Given this list of marker genes Skp1 (NCBI Gene Id 76591), Enpp4, Ank, Kitl, Cd36, Kdm7a, Lbh, Ar, Mmp19, Efna5, Exoc6b, Nkain3, Cic, Purb, Pip4k2a, Taf7, Zfp719, Homer1, Rint1, Ro60, Adam34, Hoxa2, Kcnj14, Crebrf, Gnao1, Nxnl1, Zfp955b, Mysm1, Grip1, Cbln2 (NCBI Gene Id 225810), Rab7, Msl1, Sdc2, Ikzf3, Thsd4, Nrxn1, Ints8, Med14, Ms4a6c, Pfkfb4, Pgbd1 (piggyBac transposable element derived 1), Tmtc1, Cxcl9, Ednrb, Siglecg, Emb, Mfhas1 (malignant fibrous histiocytoma amplified sequence 1), Garem1, Gdf6, Bnc2, Tent5a, Grm3, Palld, Retn, Hlf, Adora2b, Slc7a11, Rsad2, Zic4, Dmd, Apobec3, Scn3a, Med13, Cln5, Oscp1, Pak3, Sav1, Ctps2, P2rx7, Zmynd8, Gtf2h2, Kcnj13, Bcl11a (BCL11 transcription factor A), Gng2, Cdc42ep3, Adcyap1, Ints12, B3gat1, Cycs, Car13, Pamr1, Scn8a, Map2k7, Prg4, Zbtb7a, Chpt1, Socs6, Sult6b1, Sc5d, Rabgap1l, Cacul1, Slc4a10, Dcdc2a, Gabpa, Fyttd1, Usp9x, Cst12, Zbtb20, Fbxl2, Col23a1, Srsf5, Cdh7, Fosb (FBJ osteosarcoma oncogene B), Sp100, Xcr1, Cask, Lepr, Wwc2, Ptchd4, Zmiz1, Ccr9, Grem1, Rp2, Uqcc4, Slc22a13, Ebf1, Brinp1, Dbx2, Itgb6, F5, Zdhhc21, Ppp1r3a, Slc20a1, H2bw2, Nmur2, Kdm5b, Npy2r, Rell1, Faxc, Frk, Slain2, Zbtb4, Csmd1, Rgs20, Ahdc1, Ythdf1, Gria2, Klrb1a, Ntrk3, Maml2, Zfp704, Pde4d, Rabgap1, Desi1, Kcna4, Ghr, Elovl6, Rab14, Meig1, Dcstamp, Hmcn1, Tbx3, Pde6c, Ajap1, Cdc14b, Ceacam2, Ciita, Ago4, Ncam1, Slc24a2, Pgr, Ttyh1, Klf8, Gcnt1, Synrg (NCBI Gene Id 97682), Leprotl1, Diaph2, Cited2, Phf14, Mapk8, Ercc1, Tnrc6b, Foxp2, Nxpe3, Wif1, Cdk5r1, Sobp, Cnih3, Sppl2a, Zfp329, Bahcc1, Hs3st3b1, Pik3r3, Scyl3, Hivep3, Aldh9a1 (NCBI Gene Id 56752), Ppargc1a, Trim52, Mosmo, Ndn, Hars2, Chmp4c, Eif4ebp2, Cep170, Urgcp, Tmcc1, Vcf1, Jakmip2, Foxp1, Arrdc3, Vps16, Kera, Enpp6, Fam124b, Ugcg, Pggt1b (NCBI Gene Id 70264), Foxb1, Zfp65, Ids, Plek2, Selp, Cdcp1, Klrb1f, Cdkn1a, Des, Cacna2d1, Aldh6a1, Srebf1, Loxl4, Rufy2 (RUN and FYVE domain-containing 2), Lama3, Pde1c, Fgf13, Zfp74, Gpr153, Klf9, Cmip, Tubal3 (NCBI Gene Id 238463), Ube2r2 (ubiquitin-conjugating enzyme E2R 2), Sspn, Kcnv1, Csde1, Rbfox3 (NCBI Gene Id 65119), Zfp950, Foxd1 (NCBI Gene Id 268693), Ebf2 (early B cell factor 2), Cadm2, Prkg1, Rasgrp3 (RAS, guanyl releasing protein 3), Dvl2, Fut9 (NCBI Gene Id 14348), Smad4, Osbpl8, Ly6m, Ncbp2, Chmp2b, Git2, Apobec1, Sult1c1, Lima1, Tfap2b, Qki, Mtarc1, Rpgrip1, Sirt2, Rbbp9, Atp2b4, Cdh4, Zyg11b, Ntrk2, Tmem70, Slc16a1, Ncam2, Hoxc13, 2510009E07Rik, Dppa2, Kctd12b, Kansl3, Fgf18 (fibroblast growth factor 18), Pdcd4, Vegfa (NCBI Gene Id 22339), Dlg5, Gcsam, Top1, Zfp141, Nectin3, Pde5a, Tgfb2, Dscaml1, Cflar, Ceacam1, Slc22a5, Tcf7l1, Stxbp5, Rem1, Nceh1, Tmf1, Ubxn2b, Scn2a, Ms4a6b, Gtdc1 (glycosyltransferase-like domain containing 1), Tob2 (NCBI Gene Id 73089), Cnot4, Endod1, Fntb, Sel1l, Serpinb12, Sertad2 (SERTA domain containing 2), Pla2g2d, Dnmt3a, Nfatc1, Rcor3, Six6, Arhgap17, Serpinb1b, Cers6, Acvr2a (activin receptor IIA), Pcdh9, Etl4, Kat6b, Itpa, Lrrc31, Nalf1 (NCBI Gene Id 270028), Nrxn3, Socs2 (NCBI Gene Id 216233), Nox4, Pakap, Irx3, Dnm1l, Pwwp2a, Smad6, Atrn, Nfia, Dnajc5 (DnaJ heat shock protein family (Hsp40) member C5), Pdlim5, Speg, Adcy5 (NCBI Gene Id 224129), Nsun6, Unc79, Zfp410, Dnah5, Cfl1, Slc5a3, Dnajc25, Rpl21, Rs1, Clxn, Rprd2, Pcdh17, B3glct, Nav1 (NCBI Gene Id 408054), Wdr43, Pim1, Lrp3, Clmn, Ackr2 (NCBI Gene Id 59289), Sntg1, Ctdnep1, Ralgps2, Lrrc2, Secisbp2l, Fos, E2f5, Scarf1, Cetn3, Cdh2, Dmrta1, Hoxc6, Ifngr2, Gapt, Gnb1, Xkr6, Hoxb1, Prrt2, Haus2, Atad2b, Irx6, Alox8, Tet2, Crtc3, Slc16a14 (solute carrier family 16 (monocarboxylic acid transporters), member 14), D630045J12Rik, Ccnd2, E130311K13Rik, Hsf2bp, Rgs17, Eomes, Arl4a, Bambi, Spred2, Igsf3, Snhg11, Cacng2, Zmat2, Zfp354b, Vil1 (villin 1), Casd1, Gm5820, Tmem255a, Ano1, Adam28, Rin2, Fez2, Lrrtm3, Cemip2, Npepps, Naaladl2, Mfn1, Fnd3c2, Dennd1b, Cdc25c, Foxd4, Igfbp7, Mcu, Pou4f1, Snx13, Dnajc6, Mfsd6, Adamtsl1, Bmp2k, Slc31a2, Insc, Fbxw2, Rbms3, Elavl4, Septin6, Aasdhppt, Prr11, Tbc1d8b, Alox12, Iqce, Kctd1, Cks1brt, Slamf7 (NCBI Gene Id 75345), Hdac9, Tmem30a, Vwc2l, Usp33, Insr, Dab1, Csrnp2, Ap3m2, Kremen2, P2ry10b, Grid1, Zfp28 (NCBI Gene Id 76834), Ldb3, Onecut2, Dbpht2, Ankrd34b, St6galnac1, Tfcp2l1, Rprd1a, Pik3ca, Slc36a2, Stc1, Kif1b, Lrrfip1, Rreb1, Zfp462, Fam168a, Ddx39b, here is a description of the gene set: species: Mus musculus from publication Chen Y, Wang X (PMID 31504780) Genes predicted to be targets of miRBase v22 microRNA mmu_miR_669b_5p in miRDB v6.0 with MirTarget v4 prediction scores > 80 (high confidence targets). Mouse Gene Set: MIR_669B_5P